Given this list of marker genes Nrg1, Ube4b, Tgfb2, Dll4, Med1, Notch1, Rbpj, Eng, Nkx2-5, Hey1, Hey2 (hairy/enhancer-of-split related with YRPW motif 2), Heg1, Chd7, Bmpr1a, Foxh1, Ccm2l, Tgfbr1, here is a description of the gene set: The process in which the anatomical structures of the trabecular cardiac ventricle muscle are generated and organized. Mouse Gene Set: GOBP_VENTRICULAR_TRABECULA_MYOCARDIUM_MORPHOGENESIS studied in species Mus musculus